Given this list of marker genes PLK1, TUBB4B, CNTRL, CLASP1, PLK4, CPAP, CEP131, CSNK1D, PPP2R1A, CEP78, CEP43, CDK5RAP2, ACTR1A, HAUS5, HAUS4, HAUS7, YWHAG, HAUS2, YWHAE, CEP290, CEP250, DYNC1H1, PCNT, AKAP9, TUBB4A, ALMS1, CETN2 (centrin 2), CSNK1E, HAUS6, HAUS8, SDCCAG8, NEK2, CEP41, CEP152, TUBA4A, MAPRE1, ODF2, CDK1, SSNA1, PRKACA, OFD1, CEP72, NINL, TUBG1, DCTN2, CEP76, TUBA1A, CEP164, TUBB, PAFAH1B1, PCM1, CEP57, CCP110 (NCBI Gene Id 9738), SFI1, CEP63, NEDD1, HAUS3, CEP135, DCTN1, NDE1, HSP90AA1, HAUS1, DYNC1I2, DCTN3, PRKAR2B, CKAP5, CEP70, DYNLL1, CEP192, here is a description of the gene set: species: Homo sapiens During interphase, Nlp interacts with gamma-tubulin ring complexes (gamma-TuRC), and is thought to contribute to the organization of interphase microtubules (Casenghi et al.,2003). Plk1 is activated at the onset of mitosis and phosphorylates Nlp triggering its displacement from the centrosome (Casenghi et al.,2003). Removal of Nlp appears to contribute to the establishment of a mitotic scaffold with enhanced microtubule nucleation activity. Reactome Pathway: Loss of Nlp from mitotic centrosomes part of: Loss of proteins required for interphase microtubule organization from the centrosome